The following is a description of a gene set: Broad forehead species: Homo sapiens Width of the forehead or distance between the frontotemporales is more than two standard deviations above the mean (objective); or apparently increased distance between the two sides of the forehead. Human Gene Set: HP_BROAD_FOREHEAD, and this is the list of marker genes: LIMK1, PPP2CA, GATA6, KDR, HBA2, CHST14, CDKL5, MED13L, TTC5, GTF2IRD1, AIP, ANKH, NCF1, DPH5, CITED2, PAK1, TBCK, LRP5, HOXB1, NIPA2, TCTN2, FGFR3 (NCBI Gene Id 55546), CCNQ, MKS1, POLR3A, NF1, HES7, DPP9, NKX2-5, POGZ, RTL1, UBAP2L, FLNA, MEG3, GPC3, NRAS, RNF135, GATA4, HRAS, PIGN, RUNX2, ELN, TRPM3, IQSEC2, BRAF, TCEAL1, NIPA1, RYR3, SHOC2, CHD8, KCNJ2, THOC6, WBP11, PIGA, CUL7, ODC1, PIK3CA, FBLN5, HBA1 (hemoglobin subunit alpha 1), GTF2I, SH3PXD2B, ESAM, DLK1, NARS1, CDH11, WAC, RIPPLY2, FAT4, STX1A, FBN1, GJA5, CAMTA1, SLC6A8, POLR1A, BMP2, ROBO1, IGBP1, GATAD2B, COLEC11, IDH1, NFIA, POLE, IFIH1, STEEP1, AHDC1, MESP2, GPC4, MEF2C, SPTBN1, ALDH18A1, OBSL1, DEAF1, FLII, NALCN, PPM1D, SIN3A, NOTCH2 (notch receptor 2), FGFR2, CUX1, LRP2, CASK, UNC80, PRIM1, ZFPM2, SKIC3, GPR101, DNMT3A, MADD, PYCR1 (pyrroline-5-carboxylate reductase 1), B3GAT3, EBF3, METTL27, PTEN, MBD5, FGD1, FUT8, CCBE1, ACTG2, TUBG1, CBL, WASHC5, PEX3, RPL10, GDF1, RBM8A, TBC1D7, TBX1, TOMM7, JAG1, ABL1, PIGU, PSPH, FLCN, ZIC1, SH2B1, B4GALT7, TBL2, TFAP2B, SMAD2, LFNG, ZFX, SLC26A2, ADAMTS3, PRKACB, MAP2K1, FBXO11, KIF7, AMMECR1, BAZ1B, TET3, TMEM270, SATB2, SCNM1, FLT4, CHST3, RFC2, CKAP2L (cytoskeleton associated protein 2 like), NAA10, NSD1, EED, TAFAZZIN, ANTXR1, ACTL6B, TENT5A, RECQL4, KRAS, ZBTB20, CNTNAP2 (NCBI Gene Id 26047), FKBP6, KCNH1, SIM1, YY1 (YY1 transcription factor), TCF12, EIF4H, BRPF1, NKX2-6, THOC2, EMC10, NFIX, GTF2IRD2, CDC42BPB, PCGF2 (polycomb group ring finger 2), HECTD4, CDH2, RLIM, CCDC8, GATA5, SKIC2, SLC25A24, DNAJC30, PTPN11, MAN2B1, PTDSS1, BUD23, JARID2, VPS37D, EZH2, TWIST1, RAB34, KCNJ5, SETBP1, BMP1, CCDC22, DLL3, ZIC2, RAI1, KANSL1 (NCBI Gene Id 791085), CLIP2, SUZ12